Given this list of marker genes SFTPB, COLQ, GNPTAB, IPO8, VPS33B, DYSF, FOXF1, SLC25A12, PIGN, GPC3, SCO2 (synthesis of cytochrome C oxidase 2), GPC4, ABCA3, KDM6A, VIPAS39, BMPR2, NPHP3, NONO, PIGA, GTPBP3, SELENON, FBXL4, ALPK3, STAMBP, MYH7, CAPNS1, TTN, NKX2-6, LTBP4, LAMB2, NOTCH1, SGCG, PLXND1, ATP13A3, KMT2D, TBX1, here is a description of the gene set: Right ventricular hypertrophy In this case the right ventricle is more muscular than normal, causing a characteristic boot-shaped (coeur-en-sabot) appearance as seen on anterior- posterior chest x-rays. Right ventricular hypertrophy is commonly associated with any form of right ventricular outflow obstruction or pulmonary hypertension, which may in turn owe its origin to left-sided disease. The echocardiographic signs are thickening of the anterior right ventricular wall and the septum. Cavity size is usually normal, or slightly enlarged. In many cases there is associated volume overload present due to tricuspid regurgitation, in the absence of this, septal motion is normal. species: Homo sapiens Human Gene Set: HP_RIGHT_VENTRICULAR_HYPERTROPHY